Given this list of marker genes SLC7A1, SLC6A14 (NCBI Gene Id 282807), SLC16A10, SLC38A3, SLC7A5 (NCBI Gene Id 8140), SLC3A2 (NCBI Gene Id 6520), SLC66A1, ACE2, SLC7A8, SLC36A4, SLC25A29, SLC38A5, SLC15A4, here is a description of the gene set: Human Gene Set: GOBP_AROMATIC_AMINO_ACID_TRANSPORT The directed movement of aromatic amino acids, amino acids with aromatic ring, into, out of or within a cell, or between cells, by means of some agent such as a transporter or pore. studied in species Homo sapiens